The following is a description of a gene set: Catalysis of an oxidation-reduction (redox) reaction, a reversible chemical reaction in which the oxidation state of an atom or atoms within a molecule is altered. One substrate acts as a hydrogen or electron donor and becomes oxidized, while the other acts as hydrogen or electron acceptor and becomes reduced. species: Homo sapiens Human Gene Set: GOMF_OXIDOREDUCTASE_ACTIVITY, and this is the list of marker genes: NDUFB2, CYP2F1, GPD1L, CYB5R4, MICAL2, NLRP11, ME1, SOD1, MT-ND3, PCYOX1L, NDUFB1, KDM3A, CYP11B2, ALDH4A1, HSD3B1, HPD (NCBI Gene Id 3242), KDM4A, JMJD7, HEATR4, ETHE1, MSRB1, ADH5, FASN, MT-CO1, TXNRD2, CYP2C19, NCF1C, CH25H, P3H1, DHCR7, CYB5R2 (NCBI Gene Id 51700), ALDH1A2, GPX7, TXNDC17, STAB2, SCO2, HSD17B6, AGT, CAV1, TMX3, GSTA1 (NCBI Gene Id 2938), FOXRED2, SOD2, NDUFS4, PDIA5, NDUFB3, HBB, CRYZL1, CMAHP, OGDH, HMOX2, TM7SF2, SMOX, CYBRD1, NDUFA1, HSD11B2, LOX, ALOX15, AASS, SESN3, SESN2, P3H3, PECR, HBE1, SDR42E1, SH3PXD2B, PYCR2, NSDHL, DHRS2, COX4I1, CBR3, BDH2, NDUFA8, AKR1B1, GSTK1, HSD17B13, DLD, MLDHR, UQCRC1, MSMO1, POR, HR, MOXD1, DHRS9, AKT1, OGFOD3, PTGIS (NCBI Gene Id 5740), PYROXD1, DHCR24, ALOX5, NOX3, ALDH1A3, GFUS, DHFRP1, HBD, HSD17B2, MGST3, SELENOT (selenoprotein T), FTH1, FA2H, BCO2, CAT, CYP4V2, TYW5, DHFR, MTHFD2, KDM6B, HGD, VKORC1L1 (vitamin K epoxide reductase complex subunit 1 like 1), KDM5C, ALDH3B1, CYP26B1, FTO, H6PD, FADS2B, PDHX, UQCRFS1, ACAA1, PRDX2, CYBA, SCD5, CYP11A1, NDOR1, OGFOD2, CHCHD4, CALM3, ERO1B, CRYZ, STEAP2, MT-ND4, CYP11B1, PLOD1, KCNAB3, CRYL1, NDUFC2, SURF1, ALDH1B1, ALDH1A1, MSRB3, ACADS, ACAD11, NDUFB10, LIPF, CBR4, TBXAS1, ADH6, SH3PXD2A, VAT1L, QDPR, TPH1, LDHA (lactate dehydrogenase A), OXR1, NOS1, MPO, SQOR, TXNRD1, SCCPDH, HBA1, LOXL3, CYP2A13, GFOD2, KCNAB1, AGMO, CYP2B6, CRAT, PIR, TXNDC5, COX8A, ADH1A, GSTO1, ETFDH, MDH1B, PDGFB, MGST1, SARDH, DCT, ENOX2, ALOX12B (arachidonate 12-lipoxygenase, 12R type), NDUFB9, CYP2S1, CHDH, VKORC1, NDUFB7, ADH1B, ADH7, KIAA1191, HMOX1, WWOX, MAOA, RRM2B, FTMT, TPO, PPOX, AKR1C2, MT-ND5, DHRS13 (NCBI Gene Id 147015), PHYH, ETFA, SDR9C7, CLIC5, BCKDHB, CYB561D1, CYP2J2, PXDN, EPX, MSRB2, HPDL, PAH, DHODH, NCF4, CYP27A1, CYC1 (cytochrome c1), NDUFB8, MT-ND4L (mitochondrially encoded NADH:ubiquinone oxidoreductase core subunit 4L), CYP27B1, SDHB, PEDS1, HTATIP2, DHRS7, MIOX, UQCR10, STAB1 (NCBI Gene Id 23166), ALOX12 (NCBI Gene Id 239), SELENON, HSD17B12, IDH3G, RDH16, HIBADH, MICAL3, AKR1E2, EHHADH, MICAL1, DUS2, PHYHD1, CLIC4, KDM4C, CTBP2, ALKBH4, MT-CO3, NOXO1, PDIA2, ACOX3, P3H2, IMPDH2, ACOX2, ALDH3A1, PHF2, PLOD3, ESR1, PRDX3, CLIC3, RPE65, MTHFR, AOX1, NCF1B, CYP7B1, TXNL1, NDUFS2, P4HA3, ALOX15B, COX7A2L, PDHB, COX7B, KDM3B, HBM, DOHH, TECR, DDO, ALKBH1, PTGS2, SNCA, LDHD, CYP4F8, COX5B, PDHA2, COX7A1, NQO1, KDM6A, KDM5D, CYGB, PHGDH, MT-CYB, NOX5, RRM2, NDUFS7 (NCBI Gene Id 4727), SDR16C5, CYP4A22, IDH2, DUOX2, ALKBH6, PYCR1, DUS3L, DHRS4, MT-CO2 (mitochondrially encoded cytochrome c oxidase II), KMO, DCXR, CYP2D6, IDO1, TDO2, CYP4Z2P, DHRSX, GPX4, ACAD8, ME3, CYP3A43, SCD, COX7A2, TECRL, LDHB, PDIA4, COQ7, CYP51A1, SC5D, CYP1A1, FMO4, TYRP1, STEAP3, IDO2, CYP7A1, RSBN1, MECR, NDUFA7, FAR2 (NCBI Gene Id 55711), GPX1, MTHFD1L, DECR2, TMLHE, SOD3, TXNRD3, PAM, AIFM3, HPGD, CYP4F11, VAT1, PRDX4, DYNLL1, MT-ND1, DUS4L, PXDNL, PCBD1 (pterin-4 alpha-carbinolamine dehydratase 1), SRD5A2, NOS1AP, HBQ1, HSDL2 (hydroxysteroid dehydrogenase like 2), DECR1, CYP19A1, ALKBH7, RDH5, GFOD1, LACC1, OXNAD1, CBR1, AOC2, CYP4A11, SRXN1, ADH4, CYP2A6, CTHRC1, HBZ, CYP2C8, HBG1, MTHFD1, COX6B1, LOXL4, CYP46A1, ACOXL, PYCR3, CYP17A1, CYP2U1, P4HA1, GSTT1, HSD11B1, MTCO2P12, AKR1A1, CYP3A7, ERO1A, ALDH8A1, BBOX1, SORD, TMX1, AOC3, SRD5A1, KDM1B, NDUFA9, ALDH5A1, ALDH7A1, CYP2A7, KDM4E, GLRX2, IDH3A, SDHA, NDUFS5 (NADH:ubiquinone oxidoreductase subunit S5), NOX1, NDUFC1, PRDX5, KDM2A, OGFOD1, HEPH, COA7, L2HGDH, IYD, FMO5, AKR1C4, DHRS4L2, TMX2, VCAM1, MGST2, AKR1C3, HSD17B11, ACAD10, PDHA1, RETSAT, NOX4, TPH2, NCF2 (neutrophil cytosolic factor 2), CYP2R1, HSPBAP1, HSD11B1L, ME2, HSD17B7, GSTP1, FDXR, CPOX, IFI30 (NCBI Gene Id 126359), ALDH3A2, GSTZ1, TXN2, NDUFA4 (NCBI Gene Id 4697), IDH3B, CYP2W1, FRRS1, ADH1C, CYB561D2, ALDH18A1, AKR1C8, P4HTM (prolyl 4-hydroxylase, transmembrane), MSRA, ACAD9, DEGS2, LBR, MTRR, GPX8, COX6A2, ALKBH8, ACADVL, MMACHC, D2HGDH, MB, KDSR, TYR, ACADSB, TXNDC2, AIFM2, PLOD2, PYROXD2 (pyridine nucleotide-disulphide oxidoreductase domain 2), BLVRB, KDM5A, IPCEF1, TXNDC12, RDH8, KDM8, ALDH16A1, GFER, PDIA6, ACADM, ASPHD2, ENSG00000274276, FADS6, CYP4F3, LOXL1, GPX3, HAO2 (NCBI Gene Id 51544), MDH2, NDUFA2, AIFM1, GLRX, CYP1B1 (NCBI Gene Id 1545), P4HB, CLIC2, SUMF1, HSD17B1, HDAC6, ALDH6A1, CYB561A3, SDR39U1, CYP1A2, UGDH, ADHFE1, CYP2C9, JMJD1C, GSTO2 (NCBI Gene Id 119391), DAO, SPR, NOS3, DHRS12, CYP4F22, HSD17B3, DHRS11, DHDH, DHRS4L1, GPX6, DBH, NDUFA10, CYP21A2, DBT, FADS1, DPYD, ALDH1L1, FXN, PNPO, BDH1, KDM7A, NDUFA12 (NADH:ubiquinone oxidoreductase subunit A12), GMPR, LDHC, TXNDC8, BCO1, SELENOF, UQCRH, IL4I1, KDM5B, DEGS1, MTARC2, GSR, DUS1L (NCBI Gene Id 64118), NOXA1, HBG2, KCNAB2, RRM1, GCDH, CYB5B, COX15, PARK7, KDM2B, CDO1, HSD17B8, HIF1AN (NCBI Gene Id 84175), HSDL1, FMO2, GAPDHS, PTGR1, CYB5R1, NOS2, COX6A1, HSD3B2, EGLN2, RSAD1, PCYOX1, NNT, CYP4F12, CYP3A5, NDUFA5, UEVLD, ALDH3B2, CYB5RL, IDH1, CYP2C18, GPX2, DHRS3, CTBP1, NDUFS3, HADH, AKR1C1, SRD5A3, NQO2, CYP4B1, CYBB, CYP24A1, ENOX1, RTN4IP1, HSD17B10, G6PD, NOXRED1, LPO, SESN1, ADO, NDUFA3, RDH10 (retinol dehydrogenase 10), AMBP, PIPOX, HADHB, CYP4F2, AKR1B15, LRRK2, ALKBH3, EGLN3, RDH14, AKR1B10, PTGES, PRODH2, DHFR2, MAOB, KDM4D, TP53I3, JMJD4, CYP4X1, CBS, AOC1, BCKDHA, FMO1, LDHAL6A, PTGR2, HSD3B7, DUOX1, CLIC6, LDHAL6B, HSP90AB1, F8, RIOX1, CYP26A1, XDH, DIO2, PRDX1, ALOXE3, CCS, NDUFV3, HMGCR, KDM4F, DMGDH, GLDC, DLAT, TMX4, GLUD2, TET1, GPD2, IMPDH1, GAPDH, KDM4B, NCF1, DHTKD1, TET2, GPD1, CRYM, HSD17B14, SUOX, AKR1D1, ADI1, GMPR2, PHF8, ACTB (actin beta), HSP90AA1, ALDH1L2, HADHA, DHRS1, ASPHD1 (aspartate beta-hydroxylase domain containing 1), CYB561, NDUFV2, DIO1 (NCBI Gene Id 1733), EGLN1, ATP2B4, PRDX6, IVD (isovaleryl-CoA dehydrogenase), NDUFB4, SDHD, ACOX1, CYP8B1, PTGR3, RDH12, GPHN, PTGES2, GLUD1, RIOX2, ABCC4, CYP3A4, CYP2E1, ACADL, PTGS1 (prostaglandin-endoperoxide synthase 1), CYP26C1, SDR42E2, ALOX5AP, STEAP1, AKR7L, RSBN1L, FAXDC2, NDUFB5, HAAO, MT-ND6, PRXL2B, GRHPR, FADS2, AKR7A2, HBA2, GPX5, LOXL2, TH, QSOX1 (quiescin sulfhydryl oxidase 1), AKR7A3, SELENBP1, PGD, DIO3, NXN, MT-ND2, DHRS7C, TXN, ALDH9A1 (NCBI Gene Id 223), NDUFS6, HSD17B4, KDM1A, CYB5R3, SELENOM, QSOX2, MOXD2P, NDUFB6, PAOX, ALDH2, MTARC1, MDH1, APEX1, HEPHL1, FADS3, BLVRA, DHRS7B, TET3, CLIC1, ASPDH, JMJD6, FOXRED1, DNAJC10, ALKBH2, CYP4Z1, STEAP4, NDUFAF5, MTHFD2L, PDIA3, FMO3, RNLS, RDH11 (retinol dehydrogenase 11), SQLE (squalene epoxidase), NDUFV1, CYP20A1, CYP2G1P, LTC4S, HAO1, UQCRFS1P1, CP, CYP27C1, NDUFS8, FAR1, COX5A, SLC27A5, RDH13, ALKBH5, GSTM2, CYP39A1, NDUFA6, UTY, OGDHL, PRODH, P4HA2, COQ6, NDUFS1, ASPH, PGK1, NGB